The following is a description of a gene set: The chemical reactions and pathways resulting in the breakdown of tyrosine, an aromatic amino acid, 2-amino-3-(4-hydroxyphenyl)propanoic acid. species: Homo sapiens Human Gene Set: GOBP_TYROSINE_CATABOLIC_PROCESS, and this is the list of marker genes: IL4I1, HGD, GSTZ1, TAT, FAH, HPD